Given this list of marker genes METAP1, METAP2, ACTMAP, METAP1D, RNPEPL1 (NCBI Gene Id 58159), here is a description of the gene set: studied in species Homo sapiens Catalysis of the release of N-terminal initiator methionine from peptides. Human Gene Set: GOMF_INITIATOR_METHIONYL_AMINOPEPTIDASE_ACTIVITY